The following is a description of a gene set: part of: Generic Transcription Pathway species: Homo sapiens A classic example of bifunctional transcription factors is the family of Nuclear Receptor (NR) proteins. These are DNA-binding transcription factors that bind certain hormones, vitamins, and other small, diffusible signaling molecules. The non-liganded NRs recruit specific corepressor complexes of the NCOR/SMRT type, to mediate transcriptional repression of the target genes to which they are bound. During signaling, ligand binding to a specific domain the NR proteins induces a conformational change that results in the exchange of the associated CoR complex, and its replacement by a specific coactivator complex of the TRAP / DRIP / Mediator type. These coactivator complexes typically nucleate around a MED1 coactivator protein that is directly bound to the NR transcription factor.<p>A general feature of the 49 human NR proteins is that in the unliganded state, they each bind directly to an NCOR corepressor protein, either NCOR1 or NCOR2 (NCOR2 was previously named "SMRT"). This NCOR protein nucleates the assembly of additional, specific corepressor proteins, depending on the cell and DNA context. The NR-NCOR interaction is mediated by a specific protein interaction domain (PID) present in the NRs that binds to specific cognate PID(s) present in the NCOR proteins. Thus, the human NRs each take part in an NR-NCOR binding reaction in the absence of binding by their ligand.<p>A second general feature of the NR proteins is that they each contain an additional, but different PID that mediates specific binding interactions with MED1 proteins. In the ligand-bound state, NRs each take part in an NR-MED1 binding reaction to form an NR-MED1 complex. The bound MED1 then functions to nucleate the assembly of additional specific coactivator proteins, depending on the cell and DNA context, such as what specific target gene promoter they are bound to, and in what cell type.<p>The formation of specific MED1-containing coactivator complexes on specific NR proteins has been well-characterized for a number of the human NR proteins (see Table 1 in). For example, binding of thyroid hormone (TH) to the human TH Receptor (THRA or THRB) was found to result in the recruitment of a specific complex of Thyroid Receptor Associated Proteins - the TRAP coactivator complex - of which the TRAP220 subunit was later identified to be the Mediator 1 (MED1) homologue.<p>Similarly, binding of Vitamin D to the human Vitamin D3 Receptor was found to result in the recruitment of a specific complex of D Receptor Interacting Proteins - the DRIP coactivator complex, of which the DRIP205 subunit was later identified to be human MED1. Reactome Pathway: Nuclear Receptor transcription pathway, and this is the list of marker genes: NR2C1, HNF4A, RORB, NR2C2AP, NR2E1, NCOR1, RXRG, NCOR2, NR4A2 (NCBI Gene Id 4929), NR0B2, PGR, PPARG, NR5A2, RARG, NR2F1, NR1H4, NR2E3, ESR1, RXRB, NR0B1, ESR2, RORC, NR1I2 (NCBI Gene Id 8856), ESRRA, NRBF2, RARA, RARB, NR5A1, NR2C2, PPARA, VDR, RORA, NRBP1, NR1D2, NR1H3, NR1I3, PPARD, HNF4G, ESRRB, NR3C1, NR1H2, NR3C2, RXRA, THRA, MED1, NR6A1, THRB, NR4A3, AR, ESRRG, NR1D1, NR4A1, NR2F6